Given this list of marker genes Cbfb, Eif5a2, Socs3, Rundc3b, Dio2, Mat2a, Nanos1, Lipi, Nap1l5, Clock, Cacnb2, Stox2, Extl2, Rps6ka2, Cyb561, Fam199x, Lrrc40, Nhsl3, Fbxo45, Fnip2, Fst, Ptpn2, Ankra2, Adra2a (NCBI Gene Id 11551), Tbl1xr1, Ccdc43, Atosa, Desi2, Csnk1a1, Rap1b, Ano4, Dgkq, Ell2, Tnrc6b, Plxnc1, Lamp3, Ccne2, Chst2, Nsg1, Runx2, Nagpa, Man1a2, Tmem87a, Atxn1, Nhlh2, Ror1, Sgk3, Ago3, Atp6v0d1, Rimklb, Chka, Dnmt3a, Rfx6, Tdg, Pcdh17, Hycc2, Bnc2 (NCBI Gene Id 71498), Ap1s2, Pip4k2b, Mboat1, Lrrc17, Ypel5, Edem3, Taok1, Dact1, R3hdm1, Samd8, Ide, Amotl2, Tcp11l2, Nrk, Gm4871, Ppid, Dcun1d3, Arhgef6, Six4, Slc35d3, Rapgef4, Abcd2, Lonrf1 (LON peptidase N-terminal domain and ring finger 1), Itga8, Myo5a (myosin VA), Itgb3, Gtf2h4, Vim, Adgra3, Hbs1l, Wipf1, Cpsf6, Cilk1, Rnf220, Tab3, Elovl5, Stx2, Camk2n1, Scn9a, Snx18, Strip1, Cfap61, Adamts3, Zfp560, Nus1, Ssh2, Ptgfrn, Slc36a1, Slc15a2, Avl9, Dpysl2 (NCBI Gene Id 12934), Jakmip2, Scara5, Lrrk2, Hic2, Rab2b, Sall4, Pon2, Khnyn, Gli2, Neurl1b, Plagl2, Capn5, Zfp36l2, Carf, Nefl, Sptssb, Vip, Zdhhc17, Fam13c, Gper1, Rgs8, Eed, Snrpn, Scn8a, Vmn1r71, Epb41, Mfsd11, Tenm3, Cul2, Katnbl1, Slc35c1, Reep3, Snai1, Sox9 (SRY (sex determining region Y)-box 9), Zbtb18, Eml4, Acvr1, Tmem170b, Necap1, Nabp1, Nedd4l, Gzf1 (GDNF-inducible zinc finger protein 1), Wdr82, Zdhhc21, Nadk, Adam9, Piezo2, Tulp4, Psd3, Rarg (retinoic acid receptor, gamma), Csnk1g1, Rnf122, 4933409G03Rik, Setd5, Klf10, Tbc1d15, Flvcr1, Dcbld1, Glce, Nrg3, Siah2, Usp47, Slc38a4, Ubn1, Edn2, Cracdl, Sh3rf1, Ythdf3, Sh3pxd2a, Coq3, Pip4k2a, Lrp6, Zcchc24 (NCBI Gene Id 71918), Prps1l3, Fbxo42, Per2, Cysltr1, Slc12a6, Hycc1, Calu, Gria2, Klhl20, Rrad, Zfp521, Sec24a, Pax3, Sema6d, Pik3cd, Adamts6, 0610040J01Rik, Setd7, Itpk1, Map3k5, Tent2, Nt5e, Kctd7, Gatm, Spen, Gjc2, Atg12, Phactr2 (phosphatase and actin regulator 2), Socs1, Tmem121, Zfp770, Cthrc1, Jade3, Map3k12, Sec23a, Proser1, Tia1, Sos1, Bmp5, Irs1, Fosl2, Plekhm3, Epc2, Dpy19l1, Myo9b, Capza1, Chd1, Abcc9, Nr6a1, Cop1, Mast4, Azin1, C9orf72, Gigyf2, Naaladl2, Zfp608, Yaf2, Apba1, Celsr3, B4galt6, Ntng1, Galnt3, Ube2i, Ppp1r1c, Unc5c, Pank3, Wdr7, Nfatc3, Sema6b, Pou3f4, Foxb1 (NCBI Gene Id 64290), Cpne8, Eml1, Msi2, Bcl2l11, Pde7a, Samd4, Usp45, Ankhd1, Psmd7, Actc1, Rbm44, Prlr, Ubn2 (ubinuclein 2), Ypel2, Omg, Nrxn3, Slc35f1, Dolpp1, Actr1a, Fkbp3, Slc35f3, Pdlim5, Srsf7, Rasa1, Exoc6, Zcchc2, Elmod2, Lcorl, Rab32, Tepsin, Lin28b, Sypl1, Tle1, Usp50, Zfp420, Nlgn1, Cep350, Galr1, Syngr3, Ppp3r1, Tecrl, Six1, Sec24d, Fam43a, Esco1, Slc7a10, Kras, Cnot6, Ifi213, Bdp1 (NCBI Gene Id 544971), Macroh2a1, Map3k21, Dll4 (delta like canonical Notch ligand 4), Dlgap4, Kmt2c, Gna13, Snx33, Mybl2, Camkk2, Maml1 (NCBI Gene Id 211871), Marchf4, Zdhhc20, Ncam1, Stag2, Ptp4a1, Zbtb41, Tcstv2c, Sp4, Chl1, Plxna1, Oga, Efna3, Bcor, Gja1, Cnot9, Afap1l2, Pnkd, Znrf1, Plch1, Polr3g (NCBI Gene Id 67486), Foxg1, Asb3 (ankyrin repeat and SOCS box-containing 3), Fbxo32, Lpp, Kdm3a, Prickle1 (prickle planar cell polarity protein 1), Trp53inp1, Tbc1d10b, Tbc1d30, Mkrn3, Ascc3, Ddx19b, Ppp1r18, Lrfn2, Vopp1, Ptpn13, Ednra, Cdca7, Cyp24a1, Lhx8, Xpo1, Ap4e1, Mical1, Lgi1, Picalm, Slc35a3, Haus4, Ccnjl, Xpr1, Cth, Mafg, Arid4a, Baz2b, Ppp1r12a, Terb2, Asah1, Twf1, Mitd1, Adra1d, Pdss1, Pawr, Exo5 (exonuclease 5), Ercc6l2, Ip6k3, Zfp507, Trip12, Gmeb1, Cfl2, Trappc14, Dgkz, Klf9, Sh2b3, Evx2, Stim2, Aox2, Lpar3 (lysophosphatidic acid receptor 3), Kctd8, Stk39, Plppr4, Tasp1, Mfsd6, Gmeb2, Rfx7, Galnt2, Jph4, Tmeff1, Phtf2, Ago1, Dennd2c, Tcfl5, Pgm1, Mex3b, Dcun1d1, Ppargc1b, Rbm46, Glcci1, Xkr4, Tfdp1, Atp6v1c1, Ube2j1, Tmod2, Zbtb34, Atp2b2, Adam19, Crkl (NCBI Gene Id 68624), Irx4, Esyt3, Hectd2, Rps6ka5, Ccnt2, Apaf1, Ppargc1a, Dlgap2, Mier3, Lin7c (lin-7 homolog C, crumbs cell polarity complex component, NCBI Gene Id 99335), Zmynd8, Ddit4, Grm3, Sel1l3, Gnai1, Pcgf5, Col13a1, Cep170b, Det1, Ssx2ip, Usp37, Map3k13, Gpr180, E2f7, Tent5a, Rora, Rhebl1, Fam83f, Dock7, Smad1, Mmd, Lifr, Ppp3cb, Oxr1, Frmpd1, Gnai2, Fign, Rnf157, Ppp2r1b, Mab21l1, B3gnt5, Mfap5, Cblb, Sirt1, Polr3e, Epb41l3, Rab38, Spcs3, Rimbp2, Cand1, Rap2c, Ppp3ca, Tmem200a, Itgbl1 (NCBI Gene Id 223272), Ywhaz, Gpcpd1, Impact, A630023A22Rik, Prdm1, Cadm2, Gabrb1, Celf4, Slc30a4, Mtdh, Reep1, Tcaf3, Tnrc6a, Galnt1, Rasd1, Rassf10 (Ras association (RalGDS/AF-6) domain family (N-terminal) member 10), Trpm7, Klf8, Tnrc6c, Papola, Mcf2l, St8sia4, Slc35f4, Ppp4r4, Ube3c, Ado (2-aminoethanethiol dioxygenase), Fbln5, Ap3s1, Camta1 (NCBI Gene Id 75679), Snx16, Mttp, Rasgef1a, Gabra5, Sdad1, Dnajc13, Ddah1, Col9a3, Myh11, Mdm4, Runx1, Hecw1 (HECT, C2 and WW domain containing E3 ubiquitin protein ligase 1), Larp4, Cdh20, Stk35, Hdac9, Chd7, Becn1, Sytl4, Cep41, Atg3, Cep170, Hnrnpul2, Pdcd5, Ccn4, Gpt2, Nf1, Dsg2, Wipf3, Lmbr1l, Usp48, Septin7, Rabgap1l, Slc41a2, Pbrm1, Rgs17, Skp2, Meox2, Scn1a, Ifngr1, Chst1, Ttll7, Vkorc1l1, Slc7a6, Brd10, Zfp518a, Ankrd55, Bnc1, Limch1, Calcr, Stxbp5, Spast, Pfn2 (profilin 2), Ankrd17, Kcnmb2, Ccdc6, Dsc2, Tnxb, Elavl4, Ccnk, Edc3, Dlg5, Ptpn21, Fzd3, Jarid2, Rab23, Map3k2, Rad23b, Plekho2, Bnip3l, Kcna4, Zfp644, Camk2d, Large1, Scn2a, Cdc37l1, Nfat5, Nedd4, Ark2c, Mier2, Shoc2 (NCBI Gene Id 56392), Cadps, Slc38a2, Gldc, Ttbk1, Prkaa2, Smap1, Pcnx2 (NCBI Gene Id 270109), Snapin, Mbnl3, Bahd1, Vat1, Terf1, Stac (NCBI Gene Id 20840), Lin28a, Ric3, Septin8 (septin 8), Jdp2, Arid5b, Tet1, Lpgat1, Foxd1, Ino80d, Erg (ETS transcription factor), Vat1l, Ccdc71l, Fam91a1, Arid1a, Lox, Fhip2a, Mlxip, Mbtps2, Brwd3, Slc38a7 (NCBI Gene Id 234595), Lclat1, Rai14, Slc4a7, Map6, Rab15, Washc4, Galnt7, Rasa2, Capn7, Scn3a, Nr5a2, Il21r, Scel, Herc6, Atp2a2, Garre1, Frzb, Etaa1, Ndel1, Tmem181a, Rapgef2 (NCBI Gene Id 76089), Sema3a, Pptc7, Mzt1, Osbpl8, Elavl2, Sgcb, Ube2v2 (ubiquitin-conjugating enzyme E2 variant 2), Wwtr1, Erlin1, Cnr1, Erich5, Htr4, Brd1, Fndc3a, here is a description of the gene set: Genes predicted to be targets of miRBase v22 microRNA mmu_miR_30d_5p in miRDB v6.0 with MirTarget v4 prediction scores > 80 (high confidence targets). Mouse Gene Set: MIR_30D_5P species: Mus musculus from publication Chen Y, Wang X (PMID 31504780)